Given this list of marker genes CHEK1 (NCBI Gene Id 1111), DNAAF1, PSMC3IP (NCBI Gene Id 51769), RSPH9, NME5 (NME/NM23 family member 5), ASTL, DNAAF2, BSCL2, TOP6BL, FOXJ1, SPAG1, DNAAF3, CCDC39, DNAAF5, NEK10, DNAH9, CYB5A, DNAAF11, BLM, CFAP221, ZP2, ZP1, STK36, MSH5, TTC12, HYDIN, DNAH5, CCNO, ODAD1, NR5A1, LRRC56, PATL2, CFAP300, KASH5, GGPS1, PRLR, FOXL2 (NCBI Gene Id 668), RSPH3, ODAD4, MEIOB, DNAL1, TLE6, CFAP74, KPNA7, AGPAT2, MEN1, TRIP13, RPGR (NCBI Gene Id 6110), ODAD3, SOX9, ZP3, POF1B, DNAJB13, DNAI2, CYP19A1, WT1, FIGLA (folliculogenesis specific bHLH transcription factor), RSPH4A, CDC20, NME8, SPEF2, NLRP2, PANX1, VAMP7, DNAI1, ODAD2, SYCP2L, GAS2L2, ZFP36L2, FBXO43, OFD1, CDH23, MCIDAS, MEI1, MAP3K1, CFAP298, CCDC40, AIP, SRY, DHX37, TUBB8, MSH4, WWOX, MOS, DNAAF6, ZFPM2, WEE2, REC114, DRC1, GATA4, PGR (NCBI Gene Id 5241), DNAH1, NLRP5, DNAAF4, HSF2BP, SPATA22, NR0B1, RSPH1, CYP17A1, DNAH11, ZMYND10, GALT, BTG4, here is a description of the gene set: Human Gene Set: HP_DECREASED_FERTILITY_IN_FEMALES species: Homo sapiens Decreased fertility in females